The following is a description of a gene set: The directed movement of oligopeptides into, out of or within a cell, or between cells, by means of some agent such as a transporter or pore. Oligopeptides are molecules that contain a small number (2 to 20) of amino-acid residues connected by peptide linkages. Human Gene Set: GOBP_OLIGOPEPTIDE_TRANSPORT studied in species Homo sapiens, and this is the list of marker genes: SLC7A11, MFSD1, SLC13A3, SLC25A39, ABCC1, MGST1, SLC26A6, ABCC4, SLC15A2, SLC15A1, ABCC5, SLC15A4, SLC15A3, CA2, ABCB9 (ATP binding cassette subfamily B member 9), NHERF1, CDH17, SLC25A40 (solute carrier family 25 member 40), GJA1